The following is a description of a gene set: studied in species Homo sapiens Cervical lymphadenopathy Human Gene Set: HP_CERVICAL_LYMPHADENOPATHY Enlarged lymph nodes in the neck., and this is the list of marker genes: RAC2, TNFRSF1A, ELANE, PLCG1, DEF6, NCF2, HMOX1, RASGRP1, SLC29A3, ARPC1B